The following is a description of a gene set: An infection of the lung caused by environmental mycobacteria. Such infections can occur in individuals with predisposing lung disease or immune disease. Human Gene Set: HP_NONTUBERCULOUS_MYCOBACTERIAL_PULMONARY_INFECTION studied in species Homo sapiens Nontuberculous mycobacterial pulmonary infection, and this is the list of marker genes: CFTR, DCTN4, CLCA4, STX1A, MPEG1, SLC26A9, IRF1, CEACAM6, SLC11A1, CEACAM3, MIF, EDNRA, KCNN4 (potassium calcium-activated channel subfamily N member 4), SLC6A14, SERPINA1, TGFB1, SLC9A3, HMOX1, GCLC, HFE, GSTM3